The following is a description of a gene set: Mouse Gene Set: REACTOME_REGULATION_OF_CDH11_EXPRESSION_AND_FUNCTION Regulation of CDH11 Expression and Function species: Mus musculus, and this is the list of marker genes: Adam33, Jup, Hoxc8, Ctnnd1, Angptl4, Amot, Adam19 (ADAM metallopeptidase domain 19), Zeb2, Ilf3, Cdh11, Ctnnb1, Sp1